The following is a description of a gene set: Binds to and increases the activity of a ubiquitin ligase. Human Gene Set: GOMF_UBIQUITIN_LIGASE_ACTIVATOR_ACTIVITY studied in species Homo sapiens, and this is the list of marker genes: RBCK1, CDC20, TRIB3, CDC20B, BTRC, FZR1, CDKN1B, PTEN, PEX12, ENTREP1, PIN1